The following is a description of a gene set: Human Gene Set: HP_VEIN_OF_GALEN_ANEURYSMAL_MALFORMATION studied in species Homo sapiens Vein of Galen aneurysmal malformation is a choroidal type of arteriovenous malformation that develops between 6 and 11 weeks of gestation. It results from 1 or more arteriovenous fistulas shunting blood toward the prosencephalic vein of Markowski, the embryonic precursor of the vein of Galen. This abnormal shunt leads to progressive dilation of the vein and prevents its involution and subsequent development into the vein of Galen. Vein of Galen aneurysmal malformation, and this is the list of marker genes: PLCB4, RASA1, EDN1, EPHB4, GNAI3